Given this list of marker genes LAPTM4B, RPS12P15 (ribosomal protein S12 pseudogene 15), GEM, SLEAR, NPM1P52, MTCO1P4, RNU6-1224P, ATP5PFP3, MIR3150BHG, UQCRB, SUMO2P19, COX6C, TP53INP1, RPL30, MRPL57P7, RRM2B, LINC01298, PLEKHF2, RNU6-703P, DCAF13, PABPC1, ENSG00000253824, MIR3150B, LINC01181, IRF5P1 (interferon regulatory factor 5 pseudogene 1), UQCRB-AS1, MIR599, MIR875, OSR2, LRP12, GAPDHP62, RPS26P6, UBR5, MIR5680, MIR548A3, NCALD, RPS23P1 (ribosomal protein S23 pseudogene 1), GRHL2, RPS20P23, FBXO43, CPQ, LINC02933, BAALC-AS2, LINC02845, RNF19A, FZD6, FSBP, AZIN1, PDP1, SDC2, RNU6-1209P, MIR3151, UFM1P3, MTCO2P4 (MT-CO2 pseudogene 4), GRHL2-DT, RNU6-690P, POU5F1P2, RPL19P14, PSMA2P2, LINC02906, RBM12B-AS1, UBR5-DT, MTERF3, RN7SL350P, ENSG00000253177, NACA4P, TMEM67, ENSG00000253740, STK3, LINC03047, MTDH, CFAP418-AS1, MIR378D2, PTDSS1 (phosphatidylserine synthase 1), YWHAZ, CCNE2, MTND1P5, RN7SL563P (NCBI Gene Id 106479427), GASAL1, RNU6-1011P, POP1, RNU6-914P, RPL30-AS1, VIRMA-DT, TRIQK, TMEM69P1, NIPAL2, ENSG00000238372, RN7SL685P, MAILR, SRSF3P2, CIBAR1-DT, NDUFAF6, RPL5P24, CDH17, DCSTAMP, DPYS, PDCL3P2, BAALC-AS1, MIR378D2HG, KLF10, ATP6V1C1, RNU7-67P, RNA5SP274, GDF6, RAD54B, FLJ46284, MIR7705, CFAP418, VPS13B-DT, RBM12B, MSL3P3, SNX31, DPY19L4, ZNF706, SLC25A32, KCNS2, MIR8084, RPL34P18, MATN2, BAALC, ADI1P2, ERICH5 (NCBI Gene Id 203111), GAPDHP30, CTHRC1, LINC03044, CIBAR1, LINC02844, NDUFA5P2, RNU6ATAC41P, ESRP1, MIR4471, ENSG00000296757, ANKRD46, RGS22, POLR2K, HSPE1P14, RN7SKP249, SNORA72, MIR3150A, RPL6P23, SPAG1, DUXAP2, ZFPM2, SUMO2P18, RNU6-748P, RN7SKP85, SNORD77B, PTMAP15, INTS8, RBM12B-DT, RNU6-1092P, ZNNT1, RIMS2, MYL12AP1, RIDA, VPS13B, LINC03090, RNU6ATAC8P, ODF1, RPL29P18, TSPYL5, SNORD3H, RNU6-1172P (RNA, U6 small nuclear 1172, pseudogene), LINC02894, ZNF317P1, VIRMA, RNU4-83P, RPS4XP10, here is a description of the gene set: species: Homo sapiens Human Gene Set: chr8q22